Given this list of marker genes ARL4C, CD3D, CRIP1, BIN1, TCF7, KLRC2, LTB, ZNF496, CYFIP2, SOX10, CDC25B, SMPD1, GZMH, SERPINF1, RPL37, CD79B, IL18, ITM2A, LIMCH1, ITPKB, INPP4B, ADSL, CD8B, PRSS1, F11R (NCBI Gene Id 50848), WDR54, RPA2, GZMK, NCAM1, IL16, PHF20, MS4A1, RGS14, RPS3A, CD99, PPP6C, RPL23A, IGLL1, NR1D1, CD1C (NCBI Gene Id 911), MRPS21, HINT1, RNASE6, RPS21, COL21A1, FBLN5, PEBP1, ALOX5AP (arachidonate 5-lipoxygenase activating protein), PCED1B, ECI2, TPD52, ZNF211 (zinc finger protein 211), LAT, EIF2S1, RASGRP2 (RAS guanyl releasing protein 2), ALDH3A1, RPS18, RPL35, NSG1, GZMB, IL11RA, CD19, SKAP1, P2RX5, ESYT1, B4GALT3, CBLB, SRPK2, RPL12, FCGBP, GZMM (NCBI Gene Id 3004), CCR7, CHML, SNRPN, TAF7 (NCBI Gene Id 93080), GATA3, CBX7, TOM1L1, TNPO1, RPS28, ADH5, C12orf57, IGKC, MAX, TCL1A (NCBI Gene Id 8115), CCDC107, KLRB1, A2M, RPS10, TMEM8B (NCBI Gene Id 92973), CD2, SH2D1A (NCBI Gene Id 4068), RPS16, NAP1L4, AKR1B1, RPL10A, KMT2A, MDC1, POC1B, PHYHIP, KIF22, DGKD, RPS4Y1, NELL2, KCNN4, IL18RAP, PRKCQ, DLX4, AXIN1 (NCBI Gene Id 8312), DBF4, SPTBN1, ZNF266, LCK, SLC38A1, PRKCH, PASK, MDN1, GRAP, SNHG32, HSPA4, LDHB, TTK, ZAP70, VARS2, TARP, PDE3B, TRAF3IP3, ABCC5 (NCBI Gene Id 10057), TCF3, GZMA, ABLIM1, TTC3, IL24, LLGL2, IGHG1, HADH, ATP5PO (ATP synthase peripheral stalk subunit OSCP), FOXO1, DCAF8, ATP2B4, IL7R, KAT6A, TTC9, DEXI, RPL13, HUNK, OSER1, ITGAE, CD8A, SAE1, CCL5, RPS27, EI24, IL18R1, ZNF526, CD3G, PUF60 (poly(U) binding splicing factor 60), KLRC3, DGUOK, TXK, SORL1, CLIC4 (chloride intracellular channel 4), SPOCK2, ICAM3, RHOH, UBB, TMC6, ZNF692, RPS15A, RETREG3, EXPH5, RPS29, HYAL2, SPIB, FLNB, FGFBP2, EEF1B2, RPL9, RAB33A, RPL13A, DHRS3, TSPAN4, TACR1, MRNIP, XYLB (NCBI Gene Id 9942), PELP1, XIAP, RPL14, here is a description of the gene set: Gene expression in human peripheral blood mononuclear cells was systematically evaluated following smallpox and yellow fever vaccination, and naturally occurring upper respiratory infection (URI). All three infections were characterized by the induction of many interferon stimulated genes, as well as enhanced expression of genes involved in proteolysis and antigen presentation. Vaccinia infection was also characterized by a distinct expression signature composed of up-regulation of monocyte response genes, with repression of genes expressed by B and T-cells. In contrast, the yellow fever host response was characterized by a suppression of ribosomal and translation factors, distinguishing this infection from vaccinia and URI. No significant URI-specific signature was observed, perhaps reflecting greater heterogeneity in the study population and etiological agents. Taken together, these data suggest that specific host gene expression signatures may be identified that distinguish one or a small number of virus agents. studied in species Homo sapiens from publication Scherer CA, Magness CL, Steiger KV, Poitinger ND, Caputo CM, Miner DG, Winokur PL, Klinzman D, McKee J, Pilar C, Ward PA, Gillham MH, Haulman NJ, Stapleton JT, Iadonato SP (PMID 17651872) Human Gene Set: SCHERER_PBMC_APSV_WETVAX_AGE_18_32YO_5_TO_7DY_DN Genes down-regulated in peripheral blood mononuclear cell (5 to 7)d vs 0d in adults (18-32) after exposure to APSV Wetvax, time point 5 to 7D